Given this list of marker genes Aprt, Dpys, Dpyd, Pnp, Pygl, Pnp2, here is a description of the gene set: Mouse Gene Set: GOMF_NUCLEOBASE_BINDING species: Mus musculus Binding to a nucleobase, any of a class of pyrmidines or purines, organic nitrogenous bases.